The following is a description of a gene set: species: Homo sapiens Reactome Pathway: Defective F9 activation Deficiency or dysfunction of FIX leads to hemophilia B (HB), an X-linked, recessive, bleeding disorder. On a molecular basis, HB is due to a heterogeneous spectrum of mutations spread throughout the F9 gene (Rallapalli PM et al. 1989; Monroe DM et al. 1989; Suehiro K et al. 1989; Diuguid DL et al. 1989; Bertina RM et al.1990). In addition, naturally occurring point mutations in the FIX propeptide sequence such as N43Q, N43L or N46S are also annotated here. These FIX variants are secreted into the circulation with a mutant 18-amino acid propeptide still attached (Bentley AK et al. 1986; Galeffi P & Brownlee GG 1987). The unprocessed FIX variants were found to affect the function of the protein by destabilizing the calcium-induced conformation of FIX (Wojcik EG et al. 1997) and showed delayed activation by FXIa (Liddell MB et al. 1989; Ware J et al. 1989; de la Salle C et al. 1993; Wojcik EG et al. 1997; Bristol JA et al. 1993).<br><br><br> part of: Defective factor IX causes hemophilia B, and this is the list of marker genes: GP9, F9, F11, GP1BA, GP1BB, GP5